Given this list of marker genes CDKN2C, MEN1, PIK3CA, TSC1, HRAS, SDHB, PMS2, PLCD1, CDKN1A (cyclin dependent kinase inhibitor 1A), IFNG, KRAS, TSC2 (TSC complex subunit 2), KRT17, CDKN1B, SDHC, TGFBR2, PMS1, NRAS, SEC23B, MSH6, PTEN, SDHD, USF3 (NCBI Gene Id 205717), MLH1, SUFU, AKT1, KLLN, MSH2, CDKN2B, EPCAM, here is a description of the gene set: Angiofibroma consist of many often dilated vessels. Angiofibromas Human Gene Set: HP_ANGIOFIBROMAS species: Homo sapiens